The following is a description of a gene set: Hypocalciuria Human Gene Set: HP_HYPOCALCIURIA species: Homo sapiens An abnormally decreased calcium concentration in the urine., and this is the list of marker genes: KCNJ10, SLC12A3, GNA11, AP2S1, PHEX, CLCNKB, CYP27B1, FXYD2, CASR, FAM20A, CLDN10